The following is a description of a gene set: Increases the activity of a protein tyrosine kinase, an enzyme which phosphorylates a tyrosyl phenolic group on a protein. Human Gene Set: GOMF_PROTEIN_TYROSINE_KINASE_ACTIVATOR_ACTIVITY studied in species Homo sapiens, and this is the list of marker genes: IGF2, ABI1, DGKQ, IGF1, EREG, ALK (ALK receptor tyrosine kinase), STAP1, ERBB3, AREG, AFAP1L2 (actin filament associated protein 1 like 2), VEGFA, IL6ST, GREM1, GHR, BTC, HBEGF, GRM5, ALKAL2, TGFA, EPGN, ANGPT4, CD24, LTK, SRC, ALKAL1, ERCC6, PAK2, EGFR, GHRL, HTR2A, EGF, NGF, NRG3, EFNA5, CCL5, NRG1